Given this list of marker genes Pomt1, Pomt2, Dag1, here is a description of the gene set: This event has been computationally inferred from an event that has been demonstrated in another species.<p>The inference is based on the homology mapping from PANTHER. Briefly, reactions for which all involved PhysicalEntities (in input, output and catalyst) have a mapped orthologue/paralogue (for complexes at least 75% of components must have a mapping) are inferred to the other species. electronically inferred by orthology from the curated human pathway part of: DAG1 glycosylations Reactome Pathway: DAG1 core M1 glycosylations species: Mus musculus